Given this list of marker genes SPTLC2, SLC38A6, KLHL18, PARP6, FBP2, LGALS3BP (galectin 3 binding protein), C18orf32, PSPC1, DYSF, GRN, MPO, SHISA5, SCO2, STARD4, NEXN, AMELX, DHX58, OASL, TCN2, CCNL1, TUBA1B, RHEB, H2AJ, SIGLEC1, DOCK8-AS1, CAPN2, OAS2, ISG15, GMPR, MX2, RAB5IF, TRIM6, BAMBI, TRMT5, UBC, PLSCR1, HERC6 (NCBI Gene Id 55008), SERPING1, RNASE3, COX8A, OLFM4, PEDS1, PGAM1, PRMT3, CTNNAL1, MICU1, TTK, NAPA, C2, S100A11 (S100 calcium binding protein A11), FCN1, PLBD1, NT5C3A, PARP12 (poly(ADP-ribose) polymerase family member 12), IFI44, RHOG, RBX1, S100A6, PATL1, TRIM22, ZNF326, CDCA4, RELB, KLHDC7B, FXYD6, IFITM1, TMEM255A, MS4A4A, IFI44L, NXT1, CREG1, SH3GLB1, LY6E, MN1, CIMAP1B, MX1, HELZ2, MT2A, USP18, LSM1, C1QC, H2BC21, SHFL, OTOF, IFI35, BTG3, E2F2, TLR2, MTHFD2, NCOA7 (NCBI Gene Id 135112), PRC1, TMEM167A, H1-10, RSAD2 (NCBI Gene Id 91543), CTSD, UQCRFS1, CENPN, SIRPB1, FTL, CTSL, HMGN2, GNG5, C10orf71, RAB1A, H2AC14, MGRN1, MEIS3P1, MASTL, ATP5F1D, EXOSC9, H1-0, BRCA2, ARL8A, EPSTI1, IRF7, CALM3, PIWIL4 (piwi like RNA-mediated gene silencing 4), LMNB1, HERC5, HPSE, MVB12A, SPATS2L, CCNK, SRP14, XAF1, UBE2F, PELO, ARF4, DOK3, PLIN3, TUBA1C, ZBP1, C4orf33, DDX60, HMGB2, LTV1, MYD88, EIF2AK2, MTFR2, LTF, MTHFD1L, B2M, TAF9, LAMP3, NUDT15, IFI27, LINC00487, RNASE1, CENPU, FAS, CHMP5, S100A9, SAT1, UBE2A, OAS3, SPHK1, IL10, MMP8, DOT1L, IFITM2, TRIP6, SLC9A8, MICB, SUMO3, S100A8, FNDC3A, LDLR, REC8, CDCA5, IFITM3, SIRPD (NCBI Gene Id 149803), WDR26 (NCBI Gene Id 80232), MOV10, RAC1, RNF126P1, H2AC13, IFI6 (NCBI Gene Id 2537), ATOX1, RABGGTB, LDHA, MAP1LC3B, CMPK2, NECTIN2, H1-2, AGRN, PLAC8, MT1E, FERMT3, SLBP, ERO1A, STX1A, H2BC5, CCNH, RNASE2, KCTD14, XPNPEP1, TFRC, PIGB, ALAS1, ADM, here is a description of the gene set: To study the transcriptional profile of patients with acute RSV or Influenza infection,children of median age 2.4 months (range 1.5-8.6) hospitalized with acute RSV and influenza virus infection were offered study enrollment after microbiologic confirmation of the diagnosis. Blood samples were collected from them within 42-72 hours of hospitalization. We excluded children with suspected or proven polymicrobial infections, with underlying chronic medical conditions (i.e congenital heart disease, renal insufficiency), with immunodeficiency, or those who received systemic steroids or other immunomodulatory therapies. The RSV cohort consisted of 51 patients with median age of 2 months (range 1.5-3.9) and the influenza cohort had 28 patients with median age of 5.5 months (range 1.4-21). Control samples were obtained from healthy children undergoing elective surgical procedures or at outpatient clinic visits. To exclude viral co-infections we performed nasopharyngeal viral cultures of all subjects. We recruited 10 control patients for the RSV cohort with median age of 6.7 months (range 5-10), and 12 control patients for the influenza cohort with median age of18.5 months (range 10.5-26). Genes down-regulated in comparison of peripheral blood mononuclear cells (PBMC) from healthy donors versus PBMCs from infanct with acute influenza infection. from publication Ioannidis I, McNally B, Willette M, Peeples ME, Chaussabel D, Durbin JE, Ramilo O, Mejias A, Flaño E (PMID 22398282) species: Homo sapiens Human Gene Set: GSE34205_HEALTHY_VS_FLU_INF_INFANT_PBMC_DN